The following is a description of a gene set: studied in species Mus musculus Mouse Gene Set: GOBP_POSITIVE_REGULATION_OF_CD4_POSITIVE_ALPHA_BETA_T_CELL_DIFFERENTIATION Any process that activates or increases the frequency, rate or extent of CD4-positive, alpha-beta T cell differentiation., and this is the list of marker genes: Il4ra, Prkcz, Nfkbiz, Il6, Il2rg (interleukin 2 receptor, gamma chain), Cd83, Nlrp3, Brd4, Anxa1, Ifng, Hlx, Shb, Brd2, Ccl19, Il23a, Ripk2 (NCBI Gene Id 70170), Il18, Ccr7, Irf1, Foxp3, Zbtb7b, Gimap3, Nfkbid, Gimap5, H2-Ea, Opa1, Ccr2, Sash3, Klhl25, Ep300, Socs1, Mir326, Malt1, Rara, Nckap1l, Tnfsf4 (tumor necrosis factor (ligand) superfamily, member 4), Socs5